Given this list of marker genes EOMES, NOTCH1, S1PR1, TBX19, BMP7, FOXF1, EXOC4, NCKAP1, ESRP2, FOXH1, HS3ST3B1, BMP5, KRT17, TWSG1 (NCBI Gene Id 57045), FLNA, RHOB, TMEM59L, CECR2, ARHGAP35, WDR1, MESP1, GRHL3, FOXL1, RET, GCM1, GNA13, VEGFC, BMP10, NTN1, WT1, BBS7, TMEFF2, MIR145, SH3BP1, KLHL3, ADAMTS5, ZEB2, ITGB5, SDC4, CSF1, TTC8, WNT10A, GATA4, TCF15, OSR1, OPA1, MYF5, SNAI1, NRARP, TGFBR3, MMP2, MIR221, PTCH1, FOXN1, GPI, NOG, HOXD11, TRIM28, HESX1, TOR1A, IFT52, FKBPL, PRKX, CA2, PHLDB2, DLL4, MYH7, FZD3, ZDHHC7, TTN, SLIT2, HHIP, LHX2, NPHP3, ITGA5, ETV5, GLMN, IGF1, TGFBR2, KLF4, EPHA2, SPINT2, FOXC1, SETDB2, MDM4, WNT2, SNAI2, SKI, ITGA8, ADAMTS12, NUP50, LAMA1, MTHFD1L (methylenetetrahydrofolate dehydrogenase (NADP+ dependent) 1 like), CELSR1, TNF, LMO4, SAPCD2, HOXB2, PCDH8, DKK1, CTNNBIP1, GPC3, MIR15B (microRNA 15b), FOLR1, LCP1, GREM1, RBPJ, IRX3, PFN1, TRAF3IP1, NPNT, CTSH, PLET1, LIF, AJUBA, KDM5B, SCX (scleraxis bHLH transcription factor), STARD13, TNNI3, TGFB3, SIX4, BMPR1A, GREB1L, PLXNA1, ANKRD1, KDM6B, IFT57, PIK3CD, MYL3, MYC, MSGN1, EXT1, PBX1, GLI3, CDK20, BBS4, HEY1, FGFR2, PLXNB2, NODAL, TWIST1, POU4F1, MIR16-1, PKD1, BCL10, IL10, HGF, TRAF6, TXNRD1, WNT7B, PTK7, PGR, HAND2, MSX1, PHB2, WNK4, LLGL2, TGM2, FAT1, PKP2, DSP, CLASP2, TPM1, VANGL2, IFT20, SMAD1, HOXD13 (homeobox D13), ALDH1A3, LAMA5, FOXD1, BTBD7, SMAD7, DLG5, SFRP2, SERPINB5, PTCD2, LGR5, FLG2, TLX2, MICAL2, SCRIB, ZIC3, HEYL, FZD2, GCNT3, HES5, PITX2, MIB1, RARG, TMED2 (NCBI Gene Id 10959), ZFPM2 (zinc finger protein, FOG family member 2), NHERF1, KRT28, AIRE, MTHFR, ITGB1, NGFR (NCBI Gene Id 4804), CCL11, CRB2, TIE1, DSC1, STC1, ST14, PLOD3, CFL1, ITGAX, SPECC1L, SHH, MESP2, TBX4, GCNT4, TNNI1, MET, ITGB3, FOXC2, SRF, TAF10, TBX5, ESR1, CITED1, PRKACA, TSC2, CCDC39, FUZ, EFEMP2, WNT5B, PLXND1, EXOC5, INHBA, PAX2, BRSK1, ARTN, MSX2, SRC, SEMA3C, TAL1, RPS7, PDX1, KRT25, ARHGAP12, DCHS1, APAF1, COBL, ADM, TNNT2, SEMA3E, EPB41L5, CYP7B1, OVOL2, ISL1, SEC24B, TFAP2C, MDM2, FGF10 (NCBI Gene Id 2255), UBE4B, GORAB (NCBI Gene Id 92344), PSEN1, NFATC4, EGFR, PALS1, TP63, GZF1, SUFU, WNT3A, WNT16, FZD5, GATA3, STK4, NPHP1, MYO9A, VDR, TGIF1, MYLK, MEF2C, PTEN, FKBP1A, DLG3, CTHRC1 (collagen triple helix repeat containing 1), NAGLU, RBM15, WNT5A, KIF26B, ADAMTS16, WNT1, SPRY1, TIMELESS, RHOA, DVL1, ALDH1A2, BRSK2, VEGFA, JHY (NCBI Gene Id 79864), LHX1, EDN1, ACVRL1, MKS1, TBX1, CLIC4, FRS2, TBXT, ITGA3, EPHA4, TEAD2, AGT, FOXP1 (forkhead box P1), ASB2, RPGRIP1L, ID4, MIR1-1, TBX3, SFRP1, ITGB4, HOXB13, STOX1, KLK14, HOXB7, RARA, SOX9, IHH, HS2ST1, BTRC, CDC42, SOX11, CEP290, SIX3, GDNF, TGFB2, RAB10, MIR195, NKX2-5, ZFPM1, COL3A1, ARL13B, TFAP2A, FRAS1, DLG1, FGF2, SOS1, ADARB1, KRT16, PAK1, CITED2, TNNC1, CTNND1, HMGA2, GLI2, FERMT1, LUZP1, MYH6, ACTG1, AHDC1, WDR83, LBX1, PRKAR1A, SPRY2, TSC1, PDGFA, C1orf54, LRG1, EGF, CEACAM1, EPHA7, AR, COL5A1, PODXL (NCBI Gene Id 5420), CPLANE2, FOXF2, ENG (endoglin), RDH10, HAND1, LBX2, FRZB, STK3, FGF1, KAT2A, CASR, BMP2, STAT1, LCN2, BMP4, VPS52, ACTC1, NRP1, IGFBP5, PLA2G10, TCTN1, ROBO2 (roundabout guidance receptor 2), ALX1, KDR, TRIM15, YAP1, HEY2, KRT6A, NKX2-1, CLUAP1, RALA, ACTA2, NOTO, MKKS, AREG, WNT11, WNT4, PROX1, TBX20, FIGNL2, TBX6, SOX10, CTSZ, POFUT2, MTOR, DEAF1, FOXN4, NOTCH4, SYNE4, MYL2, CTNNB1, MYBPC3, SIRT6, FST, TGFBR1, LZTS2, TGM3, SEMA4C, CSNK2B, HNF1B (HNF1 homeobox B), SALL4, FGF8, ILK, ASTN2, MMP12, FREM2, GJA1, LIN7C, CLASP1, CARMIL2, TRIM71, SPINT1, DDR1, PRKD2, FGFR1, SMAD2, MYCN, FERMT2, TACSTD2, SHOX2, CAMSAP3, EXT2, NOTCH2, CRYGS, LEF1, AGTR2, HIF1A (NCBI Gene Id 3091), SULF1, SOX17, MIR200C, EZR, CA9, VASP, GBX2, IFT122, PKD2, EFNB2, MED12, FZD6, IRX1, WNT9B, EYA1, MMP14, APELA, FEM1B, SMAD3, MATN1, APLNR, HOXA11, PAX8 (paired box 8), EDNRA, ERBB4, SIX1, KDM2B (lysine demethylase 2B), EYA2, HOXB4, ABL1, WNT7A, MIR150, RGMA, INTU, FOXE1, WDPCP, JAG2, KDF1, NOS3, CSMD1, DLC1, ACVR1, DLL1 (delta like canonical Notch ligand 1), TGFB1I1, C2CD3, GRSF1, MAGED1, MED1, ITGA2, HEG1, BSG, NF2, EGLN1, LIAS, BBS5, RREB1, HOXA13, WNT2B, NKX3-1, ACTB, RSPO2, GDF7, GRB2, CCDC40, HS3ST3A1, DVL2, MMRN2 (NCBI Gene Id 79812), PAX7, ACTG2, SLC39A12, RASIP1, KRAS, APC, HOXA5, SOSTDC1, ETV2, CXCL10, BRD2, NTN4, NR4A3, GREB1, PDCD10, HES1, CD151, TMEM100, PPP3R1, TBX2, MTSS1, TULP3, KIF20B, GDF2, SALL1, SOCS3, IRX2, CASP3, FLRT3, TGFB1, FZD1, RAP2A, MEGF8, KRT71, PRICKLE1 (prickle planar cell polarity protein 1), CCM2, CCDC103, FOXA1, TCAP (NCBI Gene Id 8557), HBEGF, KRT27, SOX18, MYF6, PKHD1, CC2D2A, OPHN1, ROBO1, COL11A1, NRG1, AHI1, RNF207, STIL, IFT172, MTHFD1, NRP2 (neuropilin 2), AJAP1, ADAM17, SOX8, MDK, SMO, NR3C1, PDPN, WLS, WNT6, PRKACB, CD44, CSF1R, FOXQ1 (forkhead box Q1), HTN1, LRP2, ACTA1, LRP5, COL4A1, PML, ITGAV, TCF21, MIR143, ATP7A, GCNT1, TBX18, TNC, RHOC (ras homolog family member C), RSPO3, SMAD4, KRT12, CHD7, MYL11, FGF7 (fibroblast growth factor 7), RIPK4, BMPR2, DLX3, DNAAF1 (NCBI Gene Id 123872), GRHL2, ARMC5, XIRP2, PHACTR4, AXIN1, PPP1CA, TMEM79, VCL, DAG1, LGR4, NKD1, SIX2, STAT5A, ARHGAP24, WNT3, NDRG4, PERP, MRTFA, GATA5, MYLK2, RYR2, PAFAH1B1, MIR21, JAG1, MSN, CAV3, BCL2, here is a description of the gene set: The process in which the anatomical structures of a tissue are generated and organized. Human Gene Set: GOBP_TISSUE_MORPHOGENESIS species: Homo sapiens